The following is a description of a gene set: Human Gene Set: GOMF_CLATHRIN_BINDING Binding to a clathrin heavy or light chain, the main components of the coat of coated vesicles and coated pits, and which also occurs in synaptic vesicles. studied in species Homo sapiens, and this is the list of marker genes: LMBRD1 (LMBR1 domain containing 1), CLINT1, TOM1, SMAP1, PIK3C2A, TRPC6, SYT7, DNER, CLTC, SYT5, TOM1L2, SCLT1, GAK, NCALD (NCBI Gene Id 93992), AFTPH, CEMIP, CLBA1, GPR107, HIP1R, CLTCL1, EPN1, LRRK2, LDLRAP1, EPN2, NSG2, TOM1L1, LRP1, HIP1, BIN1, AP2B1, NSG1, EPN3, LDLR, SYT1, SNAP91, DNAJC6, CALY, MYCBPAP, CLTA, AP1B1, ENTHD1, CLTB, AP4B1, SYT6, CD2AP, PICALM, TRPC5